Given this list of marker genes ADAMTS2, FBXO11, COL5A1, GSN, EFEMP1, COL5A2, CDH11, COL1A1, here is a description of the gene set: Blepharochalasis is characterized by recurrent, non-painful, nonerythematous episodes of eyelid edema. It has been divided into hypertrophic and atrophic forms. In the hypertrophic form recurrent edema results in orbital fat herniation through a weakened orbital septum. Most patients who have blepharochalasis present in an atrophic condition with atrophy of redundant eyelid skin and superior nasal fat pads. species: Homo sapiens Blepharochalasis Human Gene Set: HP_BLEPHAROCHALASIS